Given this list of marker genes GRK7, GUCY2D, GUCA1ANB-GUCA1A, OPN1SW, GNB1, GUCA1B, PDE6A, PCDHB13, OPN4, RHO, GNAT1, OPN1MW2 (opsin 1, medium wave sensitive 2), OPN1MW, ABCA4, GUCY2F, PDE6B, OPN1MW3, OPN1LW, PDE6G, SPTBN5, GNGT1, GRK4, GUCA1C, GRK1, GUCA1A, here is a description of the gene set: Human Gene Set: GOCC_PHOTORECEPTOR_DISC_MEMBRANE studied in species Homo sapiens Stack of disc membranes located inside a photoreceptor outer segment, and containing densely packed molecules of photoreceptor proteins that traverse the lipid bilayer. Disc membranes arise as evaginations of the ciliary membrane during the development of the outer segment and may or may not remain contiguous with the ciliary membrane.